Given this list of marker genes GRIA1, B4GALNT4, S100A3, TLR1, LMO4, SGK1, ARMC12, CDK14, STRA8, SNAI3, F2RL1, TMEM71, PRRT1, CDH13, OAS1, CLCF1, CSF3, INSL5, CKMT2, TRIM9, ABTB3, TIGD3, ACADL, IFT56, TDRD5, RAB5A, TMEM163, GOLM2, TSPAN4, IL18R1, TSPAN2, PIGR, TMEM151B (NCBI Gene Id 441151), RNF144A, LDLRAP1, CD8B, NRP1, CAMK2A, DNAH8, SORT1, CCDC120, POLR3H, HEMGN, FAM184A, SAPCD1, ACSBG1, RNASE6, FBXO5, CMAS, BAIAP3, SELPLG, PDE5A, KLHDC2, RFLNB, RIPOR1, EEPD1, AMZ1, COL27A1, C16orf87, RNF216, BPIFA2, ANGPTL2, JCAD, PLEKHF1, AUH, RRAS2, SIDT1, SLA2, CLIC4, S100A6, PTCRA, ST6GALNAC6, VMA21, PDLIM4, MIA2, OSBPL1A, MND1, ICA1L, CXXC5, GPR25, LRRC4C, GLIPR1L2, EHBP1L1, ZBTB16, EMID1 (EMI domain containing 1), RNASE4, SMPDL3A, EVI2B, SLC43A1, LPAR4, MGAT5B, TSGA10, IFNGR1, KHK, ESR1, DLL4, NFYC, SYTL3, FOXC1, PDGFD, ADGRE5, PALM, MAB21L2, PRKAG1 (NCBI Gene Id 5571), KIAA0586, ITGA4, IGSF8, KLF3, SLC22A3, PTPRG, DYNLT5, DCK, DPH5, MPEG1, PTPRK, B3GNT5, RNF34, GDAP1, MPP4, S1PR1, RNF135, GM2A (ganglioside GM2 activator), C1R, UTS2, ATP8B4 (ATPase phospholipid transporting 8B4 (putative)), CORO2A, SERPINI1, RASD1, IQCH, PLXDC1, NCMAP, PRODH, IL17RA, FOXB1, ANXA2, FAM78A, ANK3, PTPN14, ZNF385A, ZFYVE19, UACA, SLC66A3 (solute carrier family 66 member 3), PPP2R5A (protein phosphatase 2 regulatory subunit B'alpha), TMEM236, E2F7, GABRR2, SYT13, RND2, S1PR4, FBXL14, SELL, LTF, CCR2, FHL3, RBMXL2, VRK3, HHEX, ENDOU, NRF1, FAM229B, TBX18, MAN1C1, USP11, PITX2, ABCC5, MEDAG, HDAC4, ARPP21, PSMA8, CEP97, PIERCE1, VDR, MCOLN2, F2, PSTPIP2, KHDC1L, TNFAIP2, IFIT1, NFS1, TRIM11, CERCAM, ST8SIA6, PHYHD1, IL4, SCPEP1, SEPTIN4, ALDH3B1, CHRNA9, NRARP, GULP1, ART4, CRP (NCBI Gene Id 1401), CCDC18, NTRK3, CHRNA7, SLC5A9, CPEB1, NOTCH3 (NCBI Gene Id 791), TREX2, ALOX12B, here is a description of the gene set: species: Homo sapiens from publication Teng F, Zhou Y, Jin R, Chen Y, Pei X, Liu Y, Dong J, Wang W, Pang X, Qian X, Chen WF, Zhang Y, Ge Q (PMID 22022412) Genes down-regulated in comparison of SP2 thymocytes versus SP3 thymocytes. After positive selection in the thymus, the newly generated single positive (SP) thymocytes are phenotypically and functionally immature and undergo apoptosis upon antigen stimulation. In the thymic medullary microenvironment, SP cells progressively acquire immunocompetence. Negative selection to remove autoreactive T cells also occur at this stage. We have defined four subsets of CD4 SP, namely, SP1, SP2, SP3, and SP4 that follow a functional maturation program and a sequential emergence during mouse ontogeny.We used microarray to detail the global programm of gene expression during the maturation of murine CD4 single positive thymocytes Human Gene Set: GSE30083_SP2_VS_SP3_THYMOCYTE_DN